Given this list of marker genes NOS1, CACNB1, ATP1A1, KCNJ3, CACNB3, CLCN1, SCN1B, CACNG1, CACNA2D1, CACNG7, REM1, AKAP6, CACNG4, SLC30A1, NOS1AP, STAC, CACNA1D, SLC2A4, PPP3CB, KCNJ11 (potassium inwardly rectifying channel subfamily J member 11), BIN1, CACNG6, FXYD1, SCN5A, RDX, DYSF, ANK3, ATP1A2, AHNAK, STAC3, KCNJ12, KCNJ2, SLC8A1, SCN2B, SLC9A1, CACNG8, CASQ1, CAV3, SRI (sorcin), ANK2, CACNA1C, CACNA1S, ATP2B4, ATP1B1, OPRK1, AHNAK2, CAPN3, RTN2, SCN1A, CACNB2, STBD1, here is a description of the gene set: Human Gene Set: GOCC_T_TUBULE species: Homo sapiens Invagination of the plasma membrane of a muscle cell that extends inward from the cell surface around each myofibril. The ends of T-tubules make contact with the sarcoplasmic reticulum membrane.